The following is a description of a gene set: species: Homo sapiens part of: Neurotransmitter release cycle Reactome Pathway: Acetylcholine Neurotransmitter Release Cycle Acetylcholine neurotransmitter release cycle involves synthesis of acetylecholine, loading of synaptic vesicles, docking and priming of the acetyl choline loaded synaptic vesicles and then release of acetylcholine. This cycle occurs in neurons of central nervous system (CNS), peripheral, autonomic and somatic nervous system. In the CNS, the acetylcholine is released by the presynaptic neurons into the synaptic cleft where the released acetylcholine is accessible to acetylcholine receptors located on the postsynaptic neurons., and this is the list of marker genes: TSPOAP1, PPFIA2, CPLX1, SLC5A7, PPFIA1, CHAT, STXBP1, UNC13B, PPFIA4, SNAP25, SLC18A3, SYT1, RAB3A, PPFIA3, RIMS1, STX1A, VAMP2